The following is a description of a gene set: Human Gene Set: GOBP_NEURAL_PLATE_REGIONALIZATION species: Homo sapiens The pattern specification process that results in the subdivision of an axis or axes of the neural plate in space to define an area or volume in which specific patterns of cell differentiation will take place or in which cells interpret a specific environment., and this is the list of marker genes: NOG, TBX18, BMPR1A, FUZ, OFD1, SSBP3, CELSR2